Given this list of marker genes SERPING1, IDO1, BATF2, FCGR1A, FCGR1BP, IFIT3, here is a description of the gene set: Human Gene Set: CAO_BLOOD_FLUZONE_AGE_05_14YO_1DY_UP BACKGROUND: Live attenuated influenza vaccine (LAIV) and trivalent inactivated influenza vaccine (TIV) are effective for prevention of influenza virus infection in children, but the mechanisms associated with protection are not well defined. METHODS: We analyzed the differences in B-cell responses and transcriptional profiles in children aged 6 months to 14 years immunized with these 2 vaccines. RESULTS: LAIV elicited a significant increase in naive, memory, and transitional B cells on day 30 after vaccination, whereas TIV elicited an increased number of plasmablasts on day 7. Antibody titers against the 3 vaccine strains (H1N1, H3N2, and B) were significantly higher in the TIV group and correlated with number of antibody-secreting cells. Both vaccines induced overexpression of interferon (IFN)-signaling genes but with different kinetics. TIV induced expression of IFN genes on day 1 after vaccination in all age groups, and LAIV induced expression of IFN genes on day 7 after vaccination but only in children < 5 years old. IFN-related genes overexpressed in both vaccinated groups correlated with H3N2 antibody titers. CONCLUSIONS: These results suggest that LAIV and TIV induced significantly different B-cell responses in vaccinated children. Early induction of IFN appears to be important for development of antibody responses. Genes up-regulated in blood 1d vs 0d in children (0.5-14y) after exposure to Fluzone, time point 1D. Comment: ~80% of cohort were white, ~50/50 Female:male from publication Cao RG, Suarez NM, Obermoser G, Lopez SM, Flano E, Mertz SE, Albrecht RA, García-Sastre A, Mejias A, Xu H, Qin H, Blankenship D, Palucka K, Pascual V, Ramilo O (PMID 24495909) species: Homo sapiens